The following is a description of a gene set: Mouse Gene Set: GOMF_PROTEIN_MEMBRANE_ADAPTOR_ACTIVITY The binding activity of a molecule that brings together a protein or a protein complex with a membrane, or bringing together two membranes, either via membrane lipid binding or by interacting with a membrane protein, to establish or maintain the localization of the protein, protein complex or organelle. species: Mus musculus, and this is the list of marker genes: Alg14, Trabd (NCBI Gene Id 67976), Retreg3, Sun2, Akap6, Nup153, Sun5, Pex26, Hras, Get1, Retreg2, Gabarapl1, Sun3, Sun1, Spag4 (NCBI Gene Id 352950), Jup, Kras, Rb1cc1, Pdzk1, Lamtor1, Myh9, Nherf4, Rapsn, Vapb, Paqr3, Atg2a (autophagy related 2A), Syne3, Nherf1, Tpr, Epb41l3, Rragc, Bnip3, Pdcd6, Retreg1, Atg2b, Prima1, Cd53, Vapa, Atg14, Cib1, Syne2, Atg16l1, Nherf2, Rraga